The following is a description of a gene set: species: Homo sapiens Genes down-regulated in IL10 and NFKB1 knockout macrophages: unstimulated versus stimulated by IL10 and LPS. Bone marrow-derived macrophages were produced from mice lacking IL-10 alone (IL10-def) or mice lacking both IL-10 and the p50/p105 subunit of NF-kB (p50/IL10), and left unstimulated, stimulated with LPS (1 ng/ml) or stimulated with LPS and IL-10 (0.3 ng/ml). Human Gene Set: GSE19941_UNSTIM_VS_LPS_AND_IL10_STIM_IL10_KO_NFKBP50_KO_MACROPHAGE_DN from publication Yang HT, Wang Y, Zhao X, Demissie E, Papoutsopoulou S, Mambole A, O'Garra A, Tomczak MF, Erdman SE, Fox JG, Ley SC, Horwitz BH (PMID 21217011), and this is the list of marker genes: PPA2, DROSHA, AAAS (NCBI Gene Id 8086), SH3TC1, SIVA1, TTI1, MFSD13A, CRADD, EZR, MTMR3, MTM1, IL13, PPEF2, GIP, ACTN4, SIX5, GMNN, ADAP1, LRRN2, DYNLL1, RNASEL, NINJ2, PELI1, SLAMF6, STRAP, PPP4C, BRCA1, RERE, DPP4, GRAMD1B, ARL10, NRL, GNA15, CHML, BVES, OCSTAMP, UGGT2, TM4SF20, TTC39A, MINPP1, SLC25A53, CYB5RL, ERLIN1, ALYREF, GLIPR1, IPP, NFIX, PTX4, CDK4, PSME1, CENPN, AGFG1, SAMD9L, STEAP4, IFNA1, KIAA0753, FYB1, CSN2, SGSM2, CSGALNACT1, H2AX (NCBI Gene Id 3014), ABRACL, SERPINE2, ARC, TTC32, NANOG, IFT70B (NCBI Gene Id 150737), METTL16, ZMYND11, CENPQ, LRRC52, CDK1, CAVIN2, CHADL, ST8SIA6, KNL1, C12orf57, GZMB, UBE2I, TRIAP1, GALNTL5, MELK, TDRD1, APOC4, RPL11, NUP210, H1-10, AP1S3, HSD3B2, PGLYRP1 (peptidoglycan recognition protein 1), IL2, PHTF1 (putative homeodomain transcription factor 1), TAP2, SUV39H2, IFITM2, MSH2, CALHM6, PPP1R1A, DBF4, RRM1, RTTN, CD274, IDO2, IL33, HERC6, SREK1IP1, ANXA8, PARP12, NUDT6, RTEL1, ARHGEF6, CORO2A, ATOH8, KCNA3, MZB1, FKBP3, GATB, IFI27L2, SH2D3C, FAH, CASP3, CAPN3, GARIN3, PKIG, PBDC1 (polysaccharide biosynthesis domain containing 1), PTP4A2, CENPW, ERO1B, ANXA6, PDE8B, PLEKHH1, KRT31, TRIM47, FAM83G (NCBI Gene Id 650803), HERC1, ADK, TAC1, ITGB3, APOC3, FFAR2, PROM1, RBM14, NAA20, SFTPD, SHFL, RAD23A (RAD23 homolog A, nucleotide excision repair protein), INPP4B, ALCAM, SNX9, AGA, SMPD4, MORN4 (NCBI Gene Id 118812), DUSP9, MAD2L1, CD40LG, DUSP10, ACSL6 (NCBI Gene Id 56972), MCMBP, SERINC2, DCAKD, OAZ1, IRAG2, RAD21, MYPN, SLC7A9, NDE1, XPO1, CCL5, PTGER4, S100A4, TFPI2, GATA3, DCAF7, SH3D21, NUP37, SMARCA1, ATG3, OAS3, C9, MLKL, HSD17B11, JADE2 (jade family PHD finger 2), MCEMP1, ELL3, CDC45, FAAH, PDE7A, TRIM14, IFITM3, SLC26A10P, ERH, ORMDL1, IPCEF1, SAMD10, FST, PRADC1, CHRM4, OSBPL8, L3MBTL3